Given this list of marker genes MPO, MTTP, PLA2G3, ABCG1, PLA2G7, AGT, AGTR1, LIPC, PLA2G2A, APOA2, APOB, PLA2G10, PLA2G5, APOE, PLA2G2E, CETP, here is a description of the gene set: The acquisition, loss or modification of a protein or lipid within a low-density lipoprotein particle, including the hydrolysis of triglyceride by hepatic lipase, with the subsequent loss of free fatty acid, and the transfer of cholesterol esters from LDL to a triglyceride-rich lipoprotein particle by cholesteryl ester transfer protein (CETP), with the simultaneous transfer of triglyceride to LDL. Human Gene Set: GOBP_LOW_DENSITY_LIPOPROTEIN_PARTICLE_REMODELING species: Homo sapiens